The following is a description of a gene set: Binding to hemoglobin, an oxygen carrying, conjugated protein containing four heme groups and globin. species: Mus musculus Mouse Gene Set: GOMF_HEMOGLOBIN_BINDING, and this is the list of marker genes: Cubn, Hbb-y, Hbb-bh1, Lrp2, Hbb-bh2, Hbb-bh0, Slc4a1, Hp, Ahsp, Hbb-bs, Hbb-bt